Given this list of marker genes TINF2, ARL6IP6, ELP1, KIF21A, MAFB, TUBA1A, GNA11 (NCBI Gene Id 93626), COL3A1, CHN1, GRHL2 (grainyhead like transcription factor 2), FOXC1, PCYT1A, TUBB3, PMP22, TBX2, COL4A1, KRT71, GJA1, CPLX1, ITPR1, CTBP1, COL8A2, RHOA, SH3TC2 (SH3 domain and tetratricopeptide repeats 2), LETM1, PHOX2A, KCTD1, STIM1, COL25A1, GPR143, GMPPA, KRT74, PIK3R1, CPAMD8, FZD4, GFAP, POMT2 (NCBI Gene Id 29954), SALL4, TMEM67, PHOX2B, ADAMTSL4, LPAR6, ZEB1, TUBB2B, PTEN, TRPM3 (NCBI Gene Id 80036), HRAS, LAMB2, FGFRL1, MAB21L2, RB1, PITX2, OVOL2, SIN3A (SIN3 transcription regulator family member A), DDX6, OCRL, AAAS, KRT25, FBN1, NDP, MPZ, VSX1, LIPH, COL18A1, TONSL, LOXL1, ZEB2, AP3D1, RBP4, NSD2, ATOH7 (atonal bHLH transcription factor 7), PAX6, WT1, here is a description of the gene set: species: Homo sapiens An abnormality of the pupil. Abnormal pupil morphology Human Gene Set: HP_ABNORMAL_PUPIL_MORPHOLOGY